The following is a description of a gene set: Mouse Gene Set: GOMF_GLYCEROL_TRANSMEMBRANE_TRANSPORTER_ACTIVITY species: Mus musculus Enables the transfer of glycerol from one side of a membrane to the other. Glycerol is 1,2,3-propanetriol, a sweet, hygroscopic, viscous liquid, widely distributed in nature as a constituent of many lipids., and this is the list of marker genes: Aqp7, Aqp2, Aqp3, Aqp1, Aqp11, Aqp9